Given this list of marker genes Slc17a1, Mt2, Aass, Acox2, Arg2, Sult1d1, Tom1l2, Dnase1, Ccn2, Mpv17l, Klf15, Rdh16, Ndrg1, Prodh, Acnat2, Serpina1f, Slc22a12, Sord, Cyp2d26, Scd1 (NCBI Gene Id 20249), Acsm5, Klk1b27, Slc27a2, Aldh8a1, Errfi1, Ugt1a6a, Gk, Slc13a3, Egf, Ggct, Entpd5, Klk1b8, Fkbp5, Mt1, Pim3, Glul, Cyp27b1, Pter, Rdh16f2, Sgk1, Haao, Tnfrsf21, Hao2, Ugt3a1, here is a description of the gene set: Autosomal dominant polycystic kidney disease is an important cause of end-stage renal disease, for which there is no proven therapy. Mutations in PKD1 (the gene encoding polycystin-1) are the principal cause of this disease. The disease begins in utero and is slowly progressive, but it is not known whether cystogenesis is an ongoing process during adult life. We now show that inactivation of Pkd1 in mice before postnatal day 13 results in severely cystic kidneys within 3 weeks, whereas inactivation at day 14 and later results in cysts only after 5 months. We found that cellular proliferation was not appreciably higher in cystic specimens than in age-matched controls, but the abrupt change in response to Pkd1 inactivation corresponded to a previously unrecognized brake point during renal growth and significant changes in gene expression. These findings suggest that the effects of Pkd1 inactivation are defined by a developmental switch that signals the end of the terminal renal maturation process. Our studies show that Pkd1 regulates tubular morphology in both developing and adult kidney, but the pathologic consequences of inactivation are defined by the organ's developmental status. These results have important implications for clinical understanding of the disease and therapeutic approaches. from publication Piontek K, Menezes LF, Garcia-Gonzalez MA, Huso DL, Germino GG (PMID 17965720) Mouse Gene Set: PIONTEK_PKD1_TARGETS_UP Genes up-regulated during later stages of renal maturation (days P14-P16) in kidney specific knockout of PKD1. studied in species Mus musculus